The following is a description of a gene set: species: Mus musculus Mouse Gene Set: GOBP_PERIPHERAL_NERVOUS_SYSTEM_NEURON_AXONOGENESIS Generation of a long process from a neuron whose cell body resides in the peripheral nervous system. The axon carries action potential from the cell body towards target cells., and this is the list of marker genes: Tbce, Isl1, Pmp22, Nefh, Slc25a46